The following is a description of a gene set: from publication Chen Y, Wang X (PMID 31504780) studied in species Homo sapiens Human Gene Set: MIR548M Genes predicted to be targets of miRBase v22 microRNA hsa-miR-548m in miRDB v6.0 with MirTarget v4 prediction scores > 80 (high confidence targets)., and this is the list of marker genes: IRF2BP2, VWA2, CISH, LEPROT, RCC2, CHMP2B, SLC35F1, ABHD5 (NCBI Gene Id 51099), PMPCB, CDCA4, ZDHHC2, CAP1, LIN28B, ARCN1, ENPEP, DICER1, ZDHHC21, PIGN, FRMD4A, KCTD3, PPP1CB, OLFML2A, C11orf71, SH3BGRL (NCBI Gene Id 96022), ADGRG2, SEC23A, ABHD2, CBX1, POLR3G, NCOA3, LCOR, PLCL1, SRD5A2, CDH11, DNAJB14, ENPP4, BCL2L11, CAV2, ELP5, SORT1 (sortilin 1), ANKRD17, SLC35F5, SLC22A23, CAMSAP2, ZNF777, RTKN2, YTHDF3, DCANP1 (dendritic cell associated nuclear protein 1), FAM135A, CTTNBP2, RORA (RAR related orphan receptor A), PPTC7, SPAG6 (sperm associated antigen 6), MAGI3, TNRC6C, LPP, N4BP2, PXT1, PCLO, PDHA1 (pyruvate dehydrogenase E1 subunit alpha 1), CYBRD1, FTH1, SAMD8 (sterile alpha motif domain containing 8), PLPP5, CYREN, MPRIP, BRIP1, TUBB2B, BTN2A1, AFF4, OIP5, CYP4V2, ZBTB41, TPR, RIOK2, EZR, TMED7, ZNF699, RPL37, BCL11B, SMG1, F9, MAP7 (microtubule associated protein 7), TULP3, PROX1, LMNTD1, ZHX2, CERT1, MBNL3, ZYG11A, GLMN, TMEM9B, MRPL30, SLC2A14, AARS2, ZNF770, USP12, TMX4, NDUFV3, UBE2W, ADAM12, INPP4A, C1orf115, DPY19L1, NLN, SLC25A36, ZNF507, NUDT4, TFRC, RIOX1, GPM6A, CAP2, DCP2, NFYB, CNOT6L, FBXL2 (NCBI Gene Id 26008), B3GNT5, YAP1, SMNDC1, PSMA8, TEK, UNC80, SAMTOR, TCERG1, EBI3, ONECUT2, UBE2B (ubiquitin conjugating enzyme E2 B), HYCC1, DPYD, SP110, TRPC3, AMER2, CHSY1, KIAA0586, CLDN12, CEP78, EYS, ARF4, HAPLN1, CPEB2, TNPO1, CADM2, TMEM170A, ZEB1, TTC28, PCK1, ZNF420, KDM2B, CCDC71, USP15, BHLHE41, AMMECR1, PDCD6IP, DIXDC1 (NCBI Gene Id 85458), QKI, IRAK4, IQCH, STAM, RPL10, GDNF, LARP1B, MFSD6, TJP1, DSCAM, CHODL, AVL9, UBE2E3, APPBP2, SPICE1, FSD1L, PDE5A, MORC3 (NCBI Gene Id 23515), PRPF38B, SNX6, LACC1, P2RY12, PCDHB13, BACH2, FZD3, NDN, ANKRD13A, KLHL24 (NCBI Gene Id 79965), SRGN, ENSA, ITGAV, ANKS1B (ankyrin repeat and sterile alpha motif domain containing 1B)